The following is a description of a gene set: from publication Durante MA, Kurtenbach S, Sargi ZB, Harbour JW, Choi R, Kurtenbach S, Goss GM, Matsunami H, Goldstein BJ (PMID 32066986) species: Homo sapiens Human Gene Set: DURANTE_ADULT_OLFACTORY_NEUROEPITHELIUM_NK_CELLS, and this is the list of marker genes: IL2RG, RAP1B, GZMB, SRGN, CD160, TRAF3IP3 (NCBI Gene Id 80342), CD48, KLRD1, CORO1A, EMP3, CCND3, CXCR4, GZMA, CCL4 (NCBI Gene Id 6351), SH3BGRL3, UCP2, HLA-A, MYL12A, CYBA, GZMH, RAC2, KLRB1, CCL4L2, APOBEC3G, TYROBP, NKG7, CCL3, PFN1, IL2RB, MATK, TRBC1, SPN, PLEK, TMSB4X, LCP1, DUSP2, CD7, KLRF1, TRDC (NCBI Gene Id 28526), ARL4C, CD52, PTPRC, B2M, GZMM, PRF1, PLAAT4, HLA-B, PSMB9, EFHD2, CCL5, CD247, FGFBP2, LSP1, CYRIB, BIN2, CMC1, PTGDS, CLIC3, FCGR3A, CTSW, HCST, CD53, PYHIN1, IL32, SPON2, PLAC8, HOPX, CST7, HLA-C, ITGB2, GPR65, LIMD2, DOK2, CD69, FCER1G, MYO1F, ARHGDIB, EVL, PPP2R5C, XCL2, GNLY, MYOM2, IFITM2, TBC1D10C